Given this list of marker genes CYP4V2, RP1L1, CFHR1, MT-ND4L, BAP1, AIP, NF1, GUCA1A, VRK1, CDHR1, LRP2, MTTP, PCYT1A, OPA1 (NCBI Gene Id 4976), DNAJC30, CTNNB1, CARS2, RHO, MT-ND6, OPN1LW, PAK2, TPP1, SON, RLBP1, CFHR3, MT-ND2, TRAF7, APOE, SMARCE1, PRPH2, MT-ATP6, PPT1, SMO, ADAM9, MFN2, UCHL1, PROM1, SUFU, RDH5, HMBS, RAB28, SOST, SLC25A46, CLN5, TTLL5, TRAF3IP1, OAT, RIMS1, CDH23, CNGA3, TLCD3B, AKT1 (AKT serine/threonine kinase 1), IFT140, KARS1, DRAM2, CFH, CLN8, CLN6, CEP164, MT-ND4, PITPNM3, OPN1MW, PIK3CA, MT-ND5, ATXN7, FA2H, MT-CYB, NMNAT1, ZNF408, ATP1A3, SH3BP2, NDUFS2, COL18A1, UNC119, EXOSC9, EXOSC3, AGTPBP1 (NCBI Gene Id 23287), CRX, BRAF, DCN, KIAA1549, PEX7, ABCA4, IQCB1, POC1B, NF2, CACNA2D4, TNFRSF11A, CEP290 (NCBI Gene Id 9707), SMARCB1, NPHP3, ARL3, MEN1, CLN3, TGFBI, CFAP418, CHM (NCBI Gene Id 158677), EXOSC8, ATF6, TREX1, INVS, RPGRIP1, RS1, PHYH, SDCCAG8, PDGFB, AIPL1, CFI, CFAP410, CACNA1F, MT-ND1, NEU1, GUCY2D, PNPLA6, NPHP1, MERTK (MER proto-oncogene, tyrosine kinase), RPGR, NPHP4, WDR19 (WD repeat domain 19), MT-CO1, HMCN1, PRPS1, DNM1L, RAX2, TERT, MT-CO3, SEMA4A, EPRS1, C19orf12, COL17A1, RDH11, here is a description of the gene set: Progressive visual loss species: Homo sapiens Human Gene Set: HP_PROGRESSIVE_VISUAL_LOSS A reduction of previously attained ability to see.